Given this list of marker genes Mmab, Mtr, Abcd4, Mmachc, Mmaa, Amn, Mmadhc, Mtrr, Clybl (citrate lyase beta like), Cubn, here is a description of the gene set: studied in species Mus musculus Mouse Gene Set: GOBP_COBALAMIN_METABOLIC_PROCESS The chemical reactions and pathways involving cobalamin (vitamin B12), a water-soluble vitamin characterized by possession of a corrin nucleus containing a cobalt atom.